The following is a description of a gene set: studied in species Mus musculus The process in which the anatomical structure of the retina is generated and organized. Mouse Gene Set: GOBP_RETINA_MORPHOGENESIS_IN_CAMERA_TYPE_EYE, and this is the list of marker genes: Rdh13, Miat, Notch1, Ptprm, Thy1, Cfh, Ptn, Ihh, Ndp, Crb2, Sox8, Samd7, Bhlhe22, Bbs10, Gnat2, Prom1, Rbp4, Ttc8, Large1, Naglu, Crb1, Mir124a-2, Prdm1, Slc4a7, Nectin3, Alms1, Stat3, Hipk2, Mir182, Mir96, Irx5, Samd11, Rpgrip1l, Trpm1, Rorb, Mfsd2a, Lrp6, Megf11, Cabp4, Cnga3, Vsx1, Mir124a-1, Rpgr, Prox1 (NCBI Gene Id 320240), Dll1, Sdk2, Fjx1, Vsx2, Ahi1, Sox2, Lhx1, Rpgrip1, Rom1, Sox9, Pde6c, Ntrk2, Atp8a2, Ikzf1, Bhlhe23, Tfap2b, Man2a1, Mir183, Tspan12, Cdon, Nrl (neural retina leucine zipper gene), Rho, Casz1, Grk1, Cntf, Impg2, Hipk1, Lrp5 (NCBI Gene Id 16973), Calb1, Zhx2, Arl6, Sdk1, Thrb (thyroid hormone receptor beta, NCBI Gene Id 21834), Irx6, Ush1c, Dscam, Hcn1, Gnat1, Fat3 (FAT atypical cadherin 3), Rs1, Slc1a1, Vax2os, Bbs4, Rp1, Ptf1a, Dio3, Foxn4